Given this list of marker genes RDX, CARMIL1, CRACD, MTPN, TWF1, CAPZA1, CAPZB, CARMIL2, ADD1, AVIL, ADD2, VILL, SCIN, CFL1, CAPG, ASB2, TRIOBP, EPS8, VIL1, CAPZA2, CAPZA3, SVIL (supervillin, NCBI Gene Id 6840), ADD3, FLII, WASHC2C, TWF2, GSN, here is a description of the gene set: Human Gene Set: GOBP_BARBED_END_ACTIN_FILAMENT_CAPPING studied in species Homo sapiens The binding of a protein or protein complex to the barbed (or plus) end of an actin filament, thus preventing the addition, exchange or removal of further actin subunits.